Given this list of marker genes Dnah17, Dnah10, Dnah11, Dnah1, Dnah7a, Dnah5, Dynlrb2, Htt, Bicd1, Hook3, Dnaaf6rt, Dynlt4, Dync2h1, Dnah3 (dynein, axonemal, heavy chain 3), Dnhd1, Dynlt5, Dnah8, Dnaaf5, Dnaaf6, Dnah2, Dync1h1, Dnah7b, Dynll2, Dynlt1b, Dynlt2a1, Dnah14 (dynein, axonemal, heavy chain 14), Dynll1, Dnah9 (NCBI Gene Id 544786), Dynlrb1, Dnah7c, Dnah12, Trim58, Dynlt2b, BC048507, Frrs1l, Pafah1b1, Sptbn5, Dnah6, Dynlt3, Ran, here is a description of the gene set: Mouse Gene Set: GOMF_DYNEIN_INTERMEDIATE_CHAIN_BINDING Binding to an intermediate chain of the dynein complex. studied in species Mus musculus